The following is a description of a gene set: part of: Regulation of Homotypic Cell-Cell Adhesion Type II classical cadherins are comprised of five extracellular cadherin (EC) repeats in their ectodomain. The first cadherin repeat (EC1) of type II classical cadherins has two conserved tryptophan residues, at positions 2 and 4. The conserved tryptophan residues are critical for dimerization. Trans dimerization of classical cadherins occurs through a unique mechanism, called 'strand swapping', where one set of interactions in two monomers is replaced with an equivalent set of interactions in a dimer, through exchange of an N-terminal beta-strand facilitating docking of the Trp residues into a hydrophobic receptor pocket of the binding partner. This strand-swapping mechanism is aided by an intermediate non-swapped dimer, called X dimer, in accordance with the induced fit model. Type II classical cadherins include CDH5 (cadherin-5, also known as VE-cadherin, an atypical type II cadherin), CDH6 (cadherin-6, also known as K-cadherin), CDH7 (cadherin-7), CDH8 (cadherin-8), CDH9 (cadherin-9, also known as T1-cadherin), CDH10 (cadherin-10, also known as T2-cadherin), CDH11 (cadherin-11, also known as OB-cadherin), CDH12 (cadherin-12, also known as N-cadherin 2), CDH18 (cadherin-18), CDH19 (cadherin-19), CDH20 (cadherin-20), CDH22 (cadherin-22), and CDH24 (cadherin-24). For review, refer to Brasch et al. 2012, Gul et al. 2017.<br><br>Type II classical cadherins are predominantly expressed in the nervous system where they govern formation of neuronal circuits (e.g. cold perception, motor neuron bundling). In addition to homotypic dimer formation, type II classical cadherins form heterotypic dimers with other type II classical cadherins and can be divided into three specificity subgroups based on their binding preferences. The specificity subgroups correspond to the branches of the phylogenetic tree where binding between members has been retained. The first specificity subgroup includes CDH8 and CDH11, and likely CDH24, the second specificity subgroup includes CDH6, CDH9 and CDH10, and the third specificity subgroup includes CDH7, CDH12, CDH18, CDH20 and CDH22. The CDH8, CDH11, and CDH24 group does not bind to the others, while binding interactions are found within the other branches of the phylogenetic tree. Divergent type II cadherin CDH5 and CDH19 could not be placed in these specificity subgroups. species: Homo sapiens Reactome Pathway: Regulation of Expression and Function of Type II Classical Cadherins, and this is the list of marker genes: AGO3, CTNNB1, HEYL, AGO4, BHLHE22, ANGPTL4, CDH8 (NCBI Gene Id 1006), AGO2, SNAI1, MIR200C, PRDM8, CDH11, SP1, MIR451A, CDH24, FOXF1, ZC3H12A, SOX10, HOXC8, CTNND1, ADAM33, AMOT, CTNNA1, ZEB2, TNRC6B, JUP, MOV10, ADAM19 (NCBI Gene Id 8728), CDH19 (NCBI Gene Id 28513), AGO1, TNRC6C, ILF3, TNRC6A